The following is a description of a gene set: Human Gene Set: GSE25123_CTRL_VS_IL4_STIM_MACROPHAGE_UP studied in species Homo sapiens from publication Szanto A, Balint BL, Nagy ZS, Barta E, Dezso B, Pap A, Szeles L, Poliska S, Oros M, Evans RM, Barak Y, Schwabe J, Nagy L (PMID 21093321) Conditional macrophage-specific PPARg knockout mice were generated on C57Bl/6 background by breeding PPARg fl/- (one allele is floxed, the other is null) and lysozyme Cre transgenic mice. PPARg and IL-4 signaling was analyzed on bone marrow-derived macrophages. Bone marrow of 3 mice per group was isolated and differentiated to macrophages with M-CSF (20 ng/ml). 20 ng/ml IL-4 was used to induce alternative macrophage activation and 1 uM Rosiglitazone (RSG) was used to activate PPARg. From each mouse 4 samples were generated: 1. M-CSF, 2. M-CSF+RSG, 3. IL-4 and 4. IL-4+RSG. All compounds were added throughout the whole differentiation process, and fresh media was added every other day. Control cells were treated with vehicle (DMSO:ethanol). After 10 days, RNA was isolated and gene expression profiles were analyzed using Mouse Genome 430 2.0 microarrays from Affymetrix. Genes up-regulated in wildtype bone marrow-derived macrophages: control versus treated with IL4., and this is the list of marker genes: PIK3R5 (phosphoinositide-3-kinase regulatory subunit 5), ARIH2, BTD, BIN3, RFXANK, LY6D, MRPL44, GNPDA1, RSRC2, ARHGAP27, RUNX1, SESN2, PARP15 (poly(ADP-ribose) polymerase family member 15), DEPTOR, APMAP, ITGAL, LANCL3, EMC10, POLD4, LBH, DFFB, MRPL27, WDR83, LINC02481, SNRPD1, NME8, PRKCH, PRR5L (NCBI Gene Id 79899), FGFBP2, ZNF18, PSAP, BIK, IQSEC1, PRKAG2, SAP18, GZMB, FYN, DEF8, LRPAP1, NDUFB4, IGF2R, ZNF565, HS3ST3B1, CD160, HEXB, TSHZ3, GNS, BTBD6, BCL11B, ITPK1, NPC1, RASSF4, DAPK2, S100A6, SSBP3, PRKCA, HCLS1, BAG4, UQCR10, ABI3, COA6, RNF169, PLOD1, ABTB3, NDUFAF4, CYB5R4, CACHD1, USE1, SPHK1, ZNHIT1, TMEM9B, TFIP11, BCL7B, DSTN, BRMS1L, GAR1, PPARA, BRK1, ABHD6, TGFBR3, ZNF683, PCBP4, NCKAP1L, GLRX, GNAL, GON7, SKP1, JADE2, SHISA5 (shisa family member 5), JAKMIP1, GMNN, CD58, EFHD2, OAT, PTK2B, CCDC65, EBP, TRIM25, KIR3DL3, CLIC6, LINC01003, MED10, ZBTB17, SPAG5, SUPT4H1, TERF1, MYL6 (NCBI Gene Id 4637), CD247, GRAMD2B, SRSF7, NCOA6, SGF29, SGPL1 (NCBI Gene Id 8879), LAMP1, FCGR3B, NNMT (nicotinamide N-methyltransferase), TIMP1, AGTRAP, ELP6, PDCD2, CTPS1, COPS3, M6PR, ANXA4, PTPN18, PSMB7, CARD16, SLC46A3 (solute carrier family 46 member 3), CYBA, PCNT, EIF2B2, PCID2, CES1, MSN, NUDT1, ETV2, CC2D1A, MYH9, SLC43A3, MED14OS, MAD1L1, CINP, CBX1, SFT2D1, BNIP3, MORC4 (NCBI Gene Id 79710), LPAR6, MGAT1, CYTIP, GOLGA7B, PCGF6, TSPYL2, ELAVL1, UQCRFS1, ELOC, ALOX5AP, DUSP22, IFI16, CASP1, NSMF, MCM5, APLP2, HEXIM1, ZCCHC10, DTX3, DNMBP, URGCP, TGIF2LY, CHST10, FAM53B, SLC5A6, KIF20B, CERK, EXOSC6, SPOPL, NDUFB1, HIPK2, PDIA4, SAMSN1, RNF139, GAK, COQ10B, PDRG1, LILRB1, ZNF335, DMAC2, TKTL1, ATP2A3, MAST3, NPL, SPON2, MARCKSL1 (MARCKS like 1), SORCS2, AGAP1, PTCH1, COX7B, TRIM22, SNAP47, RAB11FIP5, DDOST